Given this list of marker genes Uba1, Keap1, Ube2r2, Trim71, Fbxl7, Fbxo41, Ube2l3, Lrrc41, Cdc16, Fbxl14, Asb6, Wsb1, Fbxw7, Ube2m, Rnf126, Npepps, Traf7, Ubb, Fbxo30, Ube2e1, Lnx1, Psmd12, Uba7, Ubac1, Herc1, Psmd3, Ube3b (ubiquitin protein ligase E3B), Anapc11, Anapc4, Asb1, Fbxo21, Ube2q2, Klhl11, Pja2, Ube2v2, Klhl13, Lrr1, Cdc34, Ube3d, Fbxl13, Glmn, Fbxw10, Ufl1, Siah2 (siah E3 ubiquitin protein ligase 2), Ube2q1, Btbd6, Rbbp6, Rnf115, Cul2, Nedd4, Klhl21, Mylip, Klhl5, Asb17, Fbxo32, Mkrn1, Rnf213, Herc3, Hace1, Asb10, Klhl42, Smurf2, Skp2, Trim37, Kctd6, Ube2f, Cul1, Klhl41, Ubr4, Klhl3, Psmc2, Ube2j1, Fbxl18, Ube2e2, Socs3, Ube2o, Cdc26, Gan, Ube2d2a, Znrf2, Fbxo4, Ubc, Fzr1, Sh3rf1, Trim50, Rnf41, Kbtbd7, Cblb, Kbtbd13, Fbxl4, Asb12, Unkl, Fbxw8, Rnf138, Psmb7, Psmb5, Rnf19a, Anapc10 (NCBI Gene Id 68999), Fbxw17, Anapc2, Ube3c (ubiquitin protein ligase E3C), Fbxl3, Skp1, Asb9, Trim21, Psmd1, Fbxw5, Fbxl12, Dtx3l, Dzip3, Fbxl19, Fbxl15, Arih2, Stub1, Spsb2, Fbxo17, Rbx1, Psmd6, Psma4, Ltn1, Psmd14, Fbxo6, Huwe1, Itch, Rnf217, Thop1, Rnf130, Ube2e3, Anapc1, Asb5, Cul7, Fbxo44, Psmb4, Ube2n, Psmc5, Psmc1, Fbxl21, Asb11, Psmd8, Asb7, Ube2a, Anapc5, Rnf34, Trim36, Psmb6, Asb13, Psmd11, Rnf123, Uba5, Hectd2, Rnf19b, Ube4a, Psmd7 (NCBI Gene Id 17463), Asb8, Klhl2, Psmd13, Fbxo15, Kbtbd8, Anapc7, Ubr1, Wwp1, Rnf6, Vhl, Fbxo40, Ccnf, Uba6, Ube2b, Fbxw9, Btbd1, Fbxw2, Trim41 (tripartite motif-containing 41), Ube2l6, Lrsam1, Ube2c, Asb4, Spsb1, Psmb2, Ube2d1, Rbck1, Rnf7, Rps27a, Rnf220, Trim32, Arel1, Psma6, Anapc13, Fbxo10, Fbxo22 (NCBI Gene Id 78764), Det1, Fbxo27, Psma7, Trim9, Uba3, Fbxl5, Trim39, Klhl25, Rnf182, Klhl22, Psma3, Adrm1, Cdc20, Fbxl16, Fbxw4, Smurf1, Ube2s, Eloc (NCBI Gene Id 98484), Siah1a, Ube2h, Rnf111, Socs1, Traip, Asb18, Rnf4, Rnf114, Asb14, Dcaf1, Cdc27, Psmc3, Mib2, Psma5, Ube2w, Ube2k, Lonrf1, Fbxo31, Prkn, Fbxo11, Ube3a, Cul3, Ube2j2, Lnpep, Ube2d3, Fbxo9, Uba52, Elob, Herc2, Mex3c, Rnf14, Psmb1, Psma2, Psmb3, Fbxw11, Fbxo7, Psmd2, Hecw2, Trip12, Fbxo2, Klhl20, Fbxl8, Psmc6, Uba52rt, Ubr2, Herc4, Ube2z, Asb16, Klhl9, Psma1, Ube2v1, Rnf25, Spsb4, Mgrn1, Znrf1, Fbxl20, Ube2g1, Hectd3, Rchy1, Hectd1, Cbll1, Psmc4, Herc6, Atg7, Lmo7, Cdc23, Rlim, Kctd7, Nedd4l, Pja1, Rnf144b, Ube2g2, Ubox5, Blmh (NCBI Gene Id 23826), Trim69, Trim11, Tpp2, here is a description of the gene set: Mouse Gene Set: REACTOME_ANTIGEN_PROCESSING_UBIQUITINATION_PROTEASOME_DEGRADATION Antigen processing: Ubiquitination & Proteasome degradation species: Mus musculus